The following is a description of a gene set: GF-RTK-PI3K signaling pathway. Pathway ID: N01656. Pathway type: Reference. Pathway class: nt06530 PI3K signaling. studied in species Homo sapiens Human Gene Set: KEGG_MEDICUS_REFERENCE_GF_RTK_PI3K_SIGNALING_PATHWAY Pathway Definition from KEGG: GF -> RTK -> PI3K -> PIP3 -> AKT, and this is the list of marker genes: CSF1R, VEGFA, PIK3R3, PDGFRA, FGFR4, MET, FGF5, FGFR2, FGF22, FGF21, KIT, FGF7, ANGPT1 (angiopoietin 1), EFNA3, KITLG, TEK, PIK3CB (NCBI Gene Id 5291), AKT2, FGF16, FGF23, NGFR, PIK3R1 (NCBI Gene Id 5295), EFNA1, PIK3CD, FLT3 (fms related receptor tyrosine kinase 3), ERBB4, PDGFA, NTRK2, PIK3R2, NGF, CSF1, EFNA4, FGF18, BDNF, IGF1R, FGF4, PDGFB, NTRK1, INS, FGF20, FGF6, KDR, AREG, ERBB3, EFNA2, INSR, AKT3, HGF, EGFR, FGFR3, ERBB2, PGF, AKT1, ANGPT4, FGFR1, FGF17, FGF1, NTF4, FLT4, FLT3LG (fms related receptor tyrosine kinase 3 ligand), EREG, VEGFC (vascular endothelial growth factor C), EGF, EPHA2 (EPH receptor A2), EFNA5, FGF2, FLT1 (NCBI Gene Id 2321), TGFA, FGF8, PDGFC, FGF19, NTF3, FGF10, ANGPT2, PDGFRB, FGF9, PIK3CA, VEGFB, VEGFD, FGF3, IGF2, PDGFD, IGF1